Given this list of marker genes KCNH1, LHCGR, POLR3A, FGFR1, AKT1, INSR, PLCB4, ESCO2, CYP11B1, here is a description of the gene set: Human Gene Set: HP_LONG_PENIS studied in species Homo sapiens Penile length more than 2 SD above the mean for age. Long penis